Given this list of marker genes TUBGCP6, CYFIP1, NIPA1, TUBGCP4, TUBGCP5, TUBGCP2, TUBGCP3, NIPA2, FMR1, here is a description of the gene set: 15q11.2 copy number variation syndrome studied in species Homo sapiens Human Gene Set: WP_15Q112_COPY_NUMBER_VARIATION_SYNDROME